Given this list of marker genes DRD1, DRD4, DRD3, DRD5, DRD2, here is a description of the gene set: part of: Amine ligand-binding receptors species: Homo sapiens Reactome Pathway: Dopamine receptors Dopamine receptors play vital roles in processes such as the control of learning, motivation, fine motor control and modulation of neuroendocrine signaling (Giralt JA and Greengard P, 2004). Abnormalities in dopamine receptor signaling may lead to neuropsychiatric disorders such as Parkinson's disease and schizophrenia. Dopamine receptors are prominent in the CNS and the neurotransmitter dopamine is the primary endogenous ligand for these receptors. In humans, there are five distinct types of dopamine receptor, D1-D5. They are subdivided into two families; D1-like family (D1 and D5) which couple with the G protein alpha-s and are excitatory and D2-like family (D2,D3 and D4) which couple with the G protein alpha-i and are inhibitory (Kebabian JW and Calne DB, 1979).